The following is a description of a gene set: studied in species Homo sapiens Human Gene Set: WP_TGFBETA_RECEPTOR_SIGNALING_IN_SKELETAL_DYSPLASIAS TGF-beta receptor signaling in skeletal dysplasias, and this is the list of marker genes: SMAD7, EP300, SKIL, BMP4, MAPK9 (NCBI Gene Id 5601), SMAD1, LEFTY1, TGFB1, FOS, SMAD9, STAT3, LTBP3, TGFBR3, JAK1, MIR302A, LEF1, SPP1, SMAD6, TGFBR2, BAMBI, STAT1, THBS1, TGFBR1, LIF, ADAMTSL2, NFKB1, SMAD3, ITGB6, SERPINE1, FST, JUN, CREBBP, IFNG (NCBI Gene Id 3458), SMAD2, WNT1, MAPK3, RUNX3, TNF, TFE3, SMAD5, ZEB2, RUNX2, SMAD4, FBN1, SKI, LTBP1, TGIF1, HRAS, ADAMTS10, FOXH1, INHBA, ZFYVE9 (zinc finger FYVE-type containing 9), FKBP1A (FKBP prolyl isomerase 1A), NOG, ZNF423, LEFTY2, ENG, EGF, CTNNB1